Given this list of marker genes PCDH17, FARP1, LRFN4, NTRK3, DVL1, PTEN, WNT5A, MIR431, NTNG2, GPC4, SLITRK2, BSN, GRID2, LRP4, NLGN1, FZD1, EFNB2, PTPRD, ARF6, APP, SLITRK3, IL1RAP, LRFN5, IL1RAPL2, NLGN3, EIF4G1, DKK1, MDGA1, LRRC4B, CNTN5, CLSTN3, IGSF11, SLITRK1, IL1RAPL1, CBLN1, NLGN4Y, WNT3A, LRRTM3, VPS35, LRFN3, SNCA, NLGN2, WNT7A, NRXN1, NLGN4X, PCLO, here is a description of the gene set: Human Gene Set: GOBP_PRESYNAPSE_ASSEMBLY The aggregation, arrangement and bonding together of a set of components to form a presynapse. species: Homo sapiens